The following is a description of a gene set: Mouse Gene Set: GOBP_CYCLIC_NUCLEOTIDE_CATABOLIC_PROCESS species: Mus musculus The chemical reactions and pathways resulting in the breakdown of a cyclic nucleotide, a nucleotide in which the phosphate group is in diester linkage to two positions on the sugar residue., and this is the list of marker genes: Pde7b (NCBI Gene Id 29863), Pde5a, Pde4c, Pde8a, Cnp, Pde8b, Pde10a, Pde7a, Pde2a, Pde4a, Pde1a, Pde9a, Pde4d